The following is a description of a gene set: Mouse Gene Set: GOBP_IRON_IMPORT_INTO_CELL The directed movement of iron ions from outside of a cell into the cytoplasmic compartment. This may occur via transport across the plasma membrane or via endocytosis. studied in species Mus musculus, and this is the list of marker genes: Steap2, Iscu, Steap3, Slco2b1, Lcn2, Tfr2, Slc39a14, Steap4, Ifng, Slc39a8, Slc11a2